The following is a description of a gene set: studied in species Mus musculus Mouse Gene Set: GOCC_STEREOCILIUM_TIP A distinct compartment at the tip of a stereocilium, distal to the site of attachment to the apical cell surface. It consists of a dense matrix bridging the barbed ends of the stereocilium actin filaments with the overlying plasma membrane, is dynamic compared to the shaft, and is required for stereocilium elongation., and this is the list of marker genes: Espn, Ceacam16, Tmc2, Myo3a, Nherf1, Cdc14a, Homer2, Tmc1, Pkhd1l1, Strc, Myo3b, Espnl, Cdh23, Whrn, Coro1a, Eps8l2, Lhfpl5, Eps8, Ush1c, Morn4, Pdzd7